Given this list of marker genes ASIC1, PNKD, NF1, SLC30A1, GGCX, SYT11, PRKN, here is a description of the gene set: Any process that stops, prevents, or reduces the frequency, rate or extent of the regulated release of a neurotransmitter. Human Gene Set: GOBP_NEGATIVE_REGULATION_OF_NEUROTRANSMITTER_SECRETION species: Homo sapiens